The following is a description of a gene set: Mouse Gene Set: chr8C5 studied in species Mus musculus, and this is the list of marker genes: Irx5, Gm28511, Slc6a2, Herpud1, Gm5912, Adgrg3, Ccl17, Gm2875, Gm45910, 4831440D22Rik, Zfp319, Gm36843, Mmp2, Gins3, Lpcat2, Gm3235, Gm31518, Prss54, Gm30132, Gm36670, Nlrc5, Cx3cl1, Gm31224, Psme3ip1, Ccdc113, Usb1, Mt3, Cngb1, Slc12a3, Kifc3, Mmp15, Ces1b, Cpne2, Gapdh-ps16, Gm10286, Nup93, Mir7072, Ogfod1, Rpl10-ps5, Mt1, C78859, Csnk2a2, Adgrg1, Gm28515, Gm36325, Nudt21, Gm45472, Gm24254, Gm45708, Ces5a, Ccdc102a, Irx3os, Cfap20, Mt2, Gm15889, Mir138-2, Ces1d, Irx6, Ciapin1, Mt4, Amfr, Capns2, Katnb1, Gm36380 (NCBI Gene Id 102640269), Bbs2, Gnb1-ps3, Ccl22, Dok4, 1700112L15Rik, Ces1h, Gnao1, Gm9619, 4933406B17Rik, Ces1g, Ces1e, Gm31036, Gm7418, Irx3, Ces1f, Gm28516, 4930488L21Rik, Gm39228, Ap3s1-ps2 (NCBI Gene Id 676565), Coq9, Spmip8, Pllp, Arl2bp, Crnde (NCBI Gene Id 71296), 9330175E14Rik, Ces1c, Polr2c, Adgrg5, Drc7, Rspry1, Ces1a